The following is a description of a gene set: Catalysis of the formation of phytyl group from the stepwise reduction of a geranylgeranyl group. studied in species Mus musculus Mouse Gene Set: GOMF_GERANYLGERANYL_REDUCTASE_ACTIVITY, and this is the list of marker genes: Akr1c6, Akr1cl, Akr1b7 (NCBI Gene Id 11997), Akr1c14, Akr1b10, Akr1c18, Akr1c20, Akr1b8